Given this list of marker genes CSF3R, RARA, ASXL1, RPL26, SRSF2, ICOSLG, RPL18, CXCR2 (NCBI Gene Id 3579), SRP68, IRF8, TET2 (NCBI Gene Id 57667), KIT, SF3B1, GATA1, CXCR4, here is a description of the gene set: Human Gene Set: HP_ABNORMAL_GRANULOCYTOPOIETIC_CELL_MORPHOLOGY studied in species Homo sapiens Abnormal granulocytopoietic cell morphology An anomaly of cells involved in the formation of a granulocytes, that is, of the granulocytopoietic cell.